The following is a description of a gene set: studied in species Homo sapiens Human Gene Set: HP_ERYTHRODERMA Erythroderma An inflammatory exfoliative dermatosis involving nearly all of the surface of the skin. Erythroderma develops suddenly. A patchy erythema may generalize and spread to affect most of the skin. Scaling may appear in 2-6 days and be accompanied by hot, red, dry skin, malaise, and fever., and this is the list of marker genes: DIP2B, PRF1, RBCK1, ADA, GTF2H5, CDSN, DCLRE1C, DSG1, EBP, CERS3, STXBP2, KRT10, AP1B1, MPLKIP, KIT, RNF113A, SLC27A4, TARS1, TGM1, IL2RG, FOXP3, LIPN, LIG4, KRT1, ADAM17, RAG1, ALOXE3, GJB2, SDR9C7, PNPLA1 (NCBI Gene Id 285848), MPDU1, ABCA12, SPINK5, AARS1, POLD3, STX11, CHD7, CD3D, CARS1, KLK11, CD3E, IL2RA, LSS, CD28, CD247, ERCC2, SULT2B1, ELOVL4, CYP4F22, EXTL3, CTLA4, ALOX12B, GTF2E2, ASPRV1, CARD14, RMRP, AP1S3, PSMB10, UNC13D, MBTPS2, NIPAL4, ERCC3, TNFRSF1B, IL36RN, IL7R, RAG2, TOM1, GJB3